The following is a description of a gene set: studied in species Mus musculus Thin cylindrical membrane-covered projections on the surface of an animal cell containing a core bundle of actin filaments. Present in especially large numbers on the absorptive surface of intestinal cells. Mouse Gene Set: GOCC_MICROVILLUS, and this is the list of marker genes: Msn, Ush1c, Nherf1, Lyz1, Itgav (NCBI Gene Id 76358), Dcxr, Espn, Mttp, Rdx, Bpifa1, Trpc2, Kcnj10, Adcy6, Ceacam20, Ceacam1, Myo1e, Tgfb1, Prom2, Clrn1, Myo7a, Scarb1, Cd302, Angpt1, Pdgfra, Dpep1, Fabp2, Amn1, Clic4 (NCBI Gene Id 29876), Cnp, Myo1a, Cblif, Plekhg6, Akr1b1, Car9, Atp6v1b1, Spn, Iqgap2, Muc4, Ift20, Cftr, Myo7b, Ctnnb1, Foxa1, Fscn3, Aoc3 (NCBI Gene Id 11754), Oxtr, Icam2, Erbb2, Crb1, Muc17 (NCBI Gene Id 666339), Car2, Podxl, Slc7a8, Slc27a4, Ctsl, Grxcr2, Cd24a, Prom1, Dlg1, Hyal2, Myo1b, Myo1c, Fmn2, Muc20, Cdhr5, Vil1, Myo6, Pdzk1 (PDZ domain containing 1), Stard10, Fscn1, Clca1, Grxcr1, Amn, Atp6v1a, Cd44, Atp6v1e1, Aqp5, Atp6v1b2, Ptprh, Slc34a2, Myo1g, Bbs2, Pdgfa (NCBI Gene Id 18590), Slc26a2, Exoc4, Lyz2, Nedd4, Itgb3, Gamt, Rapgef3, Cdh1, Cbr1, Ezr, Wwox, Cubn, Pdpn, Cbr1b, Slc6a6, Atp7a, Tprn, Otop1 (otopetrin 1), Slc38a4, Kif13b, Tek, Myo1d, Nfasc (neurofascin), Anks4b, Myo1h, Slc10a2, Slc7a5, Cdhr2, Calml4, Vcam1, Lrrk2, Spef1, Jam3, Myo1f (NCBI Gene Id 17916), Tbc1d10a, Lipc (NCBI Gene Id 15450), Slc7a11, Enpp7